The following is a description of a gene set: species: Homo sapiens Retinal hole A small break in the retina. Human Gene Set: HP_RETINAL_HOLE, and this is the list of marker genes: FZD4, ZNF408, NDP, LRP5, CTNNB1, BMP4, COL2A1